The following is a description of a gene set: studied in species Homo sapiens The chemical reactions and pathways involving epinephrine, a hormone produced by the medulla of the adrenal glands that increases heart activity, improves the power and prolongs the action of muscles, and increases the rate and depth of breathing. It is synthesized by the methylation of norepinephrine. Human Gene Set: GOBP_EPINEPHRINE_METABOLIC_PROCESS, and this is the list of marker genes: PNMT, SULT1A4, ATP7A, TH, SULT1A3